The following is a description of a gene set: species: Homo sapiens Human Gene Set: IRF2_01 Genes having at least one occurrence of the motif GAAAAGYGAAASY in the regions spanning 4 kb centered on their transcription starting sites. This matches the IRF2 transcription factor binding site V$IRF2_01 (v7.4 TRANSFAC)., and this is the list of marker genes: PRDX5, SIPA1, NPR3, TAP1, ATF3, TMBIM4, SORBS1, UBD, HOXA6, KCNE4, CSAD, FLT3LG, REL, VGLL4, NABP2, GSDMD, PDGFC, RIMS2, CCDC68, PSMA3, PGM5, ME3, TBX1, CAPRIN1, TMEM229B, MAP3K11, YY1AP1, NT5C3A, MITF, DAP3, GLRA1, OSM, DLG1, PIGR, TASL, TCIRG1, UPF2, ROCK1, ABHD16A, CUL2, LRATD2 (NCBI Gene Id 157638), TAPBP, CCDC6, EIF4A2, CXCL10, IFNL2, USF1, USP5, IFNL3, DDX17, PIGV, RTL9, PRDM16, DLX4, TERF2IP, MARCHF1, RFX4, IKZF2, GPR52, AGBL2, PLXNC1, RNF220, MAPK6, LDB2, FXYD5, PRKD3, TMEM108, TRMT6, IL15RA, KCNMB3, IFNB1, NR3C2, PROX1, MED13, KDM3A, IL11, PCGF5, BCL11A, RELCH, ARHGAP5 (Rho GTPase activating protein 5), CASZ1, DTX3L, PSMB8, BNC2 (basonuclin zinc finger protein 2), E2F3, TGFB3, LSM6, H4C7, ESR1, HPCAL1, ASH1L, MSX1, B2M, BHLHE22, TRMT112, PSME1, IL27, OTX1, ASPA, DLX1, RAPGEF6, TNFSF13B, SREK1, HDAC4, NDN, BST2, EGFL6, MCM8, DUSP10, BBX, ARHGEF6, LIF, KARS1, PRKD2, USP18 (ubiquitin specific peptidase 18), CDK6 (cyclin dependent kinase 6), SLC38A2, SYNE2, PSMB9, RIGI, AMER1, DNASE1L3, XAF1, TRPM3, PARP9, DEPDC7, TMPRSS5, BLK, FAM13C